The following is a description of a gene set: from publication Cui Y, Zheng Y, Liu X, Yan L, Fan X, Yong J, Hu Y, Dong J, Li Q, Wu X, Gao S, Li J, Wen L, Qiao J, Tang F (PMID 30759401) studied in species Homo sapiens Human Gene Set: CUI_DEVELOPING_HEART_C8_MACROPHAGE, and this is the list of marker genes: RGS10, IGSF6, CARD16, EVI2B, LGMN, LST1, ZFP36L2, PNRC1, FCGR1A, FYB1, LY96, PIK3AP1, PILRA, GPR34, SMAP2, FCGRT, CD36, POU2F2, LAPTM5, CXCR4, PMAIP1, ARHGAP30, ZFP36L1, HLA-H, LCP2, OTUD1 (NCBI Gene Id 220213), CD74, TBXAS1, F13A1, ARRB2, MAP3K8, MNDA, CTSB, CXCL16 (NCBI Gene Id 58191), CD37, RILPL2, C1orf162, C1QA, DOK2, RGS1, SLC2A3, JUND, RAB31, FPR1, RHOB, CREG1, MARCHF1 (NCBI Gene Id 55016), SGK1, HLA-B, ZFP36, C5AR1, GPSM3, HERPUD1, SH3BGRL3, CLEC7A, INPP5D, SIRPA, PLCB2, CSF3R, BAZ1A, JUNB, CPVL, NAMPT, PLAUR, LAIR1, RB1, SYK, DOCK2, ARHGDIB, TPM3, LILRB2, MKNK2, CNPY3, ADAP2, CD68, PLEK, HSPA1A, MFSD1, IL16, PABPC1, BASP1, HCK, NAIP, ADCY7, ITGAX, PTPN6, ARPC1B, IER5, CD163, EFHD2, GNAI2, C1QC, CTSC, HLA-DMB, GNA13, TKT, LAT2, DOCK8, FOSB, PRKCD, HCST, WIPF1, TNFRSF1B, HLA-DQB1, PLD4, IL10RA, MCL1, ITGB2, PYCARD, CASP1, TCIRG1, HLA-E, A2M, SH3KBP1, ARHGAP4, RNASE6, GMFG, CAP1, OSTF1, GRK2, GLRX (NCBI Gene Id 90885), RBM47, PLAC8, CYTH4, STK17B, SAMSN1, IER3, PRAM1, AIF1, NPC2, APBB1IP, LSP1, HLA-DMA, FMNL1, NFKBIA, STXBP2, SRGN, LCP1, DAZAP2, VSIG4, CSF1R, PSAP, RETN, CD14, REL, HLA-DRB1, DUSP1, NEAT1, FES, ATP6V0B, LYN, CX3CR1, MAN2B1, IQGAP1, GPX1, METRNL, SLCO2B1, FCGR3A, CEBPB, IL6R, GLUL, CYRIB, ADA2, CST3, ATP6V1B2, TPP1, S100A4, CD300A, HLA-DPB1, NINJ1, GADD45B, ARHGAP18, LITAF, CYBB, IKZF1, VAMP8, CD86, PREX1, PRR13, C1QB, MEF2C, UCP2, NR4A2, CD53, ELF1, CDKN1A, FOLR2, CALHM6, SLA, MS4A7, HLA-C, GLIPR1 (NCBI Gene Id 11010), RNF130 (NCBI Gene Id 55819), LPAR6, CEBPD, SERPINB1, RAC2, S100A9, C3AR1, STAB1, GRB2 (growth factor receptor bound protein 2), EVI2A, IFI30, PPP1R18, BTG2, ACTR2, ALOX5AP, RGS2, HBEGF, IQGAP2, RIN3, THEMIS2, HLA-A, NLRP3, JAML, PTPRC, BST2, LYZ, SPI1 (Spi-1 proto-oncogene), HLA-DRA, HLA-DPA1, PTPRE, RUNX1 (NCBI Gene Id 861), DUSP2, ALOX5, SH2B3, SKAP2, CD83, IL13RA1, PTGER4, MS4A6A, TYROBP, FCER1G, RNASET2, GPR183, CYBA, WAS, MSR1, IRF8, CTSS, LY86, FCGR2A, AOAH, MRC1, NCF2, KLF6, MAFB, CCL3, HPGDS, MYO1F, CTSD, MAF, CD4, ARPC4 (actin related protein 2/3 complex subunit 4), MS4A4A, SOD2 (superoxide dismutase 2), RHOG, HCLS1, CORO1A, MGAT1, ARPC3, CSTA, NCF4, FGL2, TLR2, GRN, PARVG, VSIR, S100A8, COTL1, MPEG1, PTAFR, ITGAM, B3GNT5, CXCL8